The following is a description of a gene set: A kinked appearance of the brainstem, i.e., an exaggerated flexure. Human Gene Set: HP_KINKED_BRAINSTEM studied in species Homo sapiens Kinked brainstem, and this is the list of marker genes: BLTP1, POMT1, POMT2, LARGE1, FKRP, FKTN